The following is a description of a gene set: The series of molecular signals initiated by a ligand binding to a platelet-derived growth factor receptor on the surface of a target cell, and ending with the regulation of a downstream cellular process, e.g. transcription. species: Homo sapiens Human Gene Set: GOBP_PLATELET_DERIVED_GROWTH_FACTOR_RECEPTOR_SIGNALING_PATHWAY, and this is the list of marker genes: PTPN12, FER, SRC, CBL, PTGIR, PDGFRB, IL1B, NRP1, PHF14, PDGFC, CLASP2, MYOCD (NCBI Gene Id 93649), PTPN2, MYO1E, JAK2, APOD, CBLB, PTPN1, NR4A3, PIK3C2A, PLAT, F7, TIPARP, F3, NDRG4, IL1R1, ITGB3, PDGFA, ZFAND5, TXNIP, LOX, PDGFRL, HIP1R, CSRNP1, LRP1, VEGFA, PTPN11, PDGFRA, ADIPOQ, PDGFD, FSHR, SGPL1, PLEKHA1 (pleckstrin homology domain containing A1), LRIG2, BCAR1, PDGFB (NCBI Gene Id 5155), IQGAP1, MIR638, RGS14, IFT20, CSPG4 (NCBI Gene Id 1464), SNCA, NHERF1, MIR296, HGS, STON1, ABL1, ARID5B, HIP1, MIR221, PTPRJ, SMPD3